Given this list of marker genes VAV1, KRAS, LYN, GRB2, EPOR, EPO, IRS2, CRKL, HRAS (HRas proto-oncogene, GTPase), SHC1, NRAS, SOS1, RAPGEF1, JAK2, here is a description of the gene set: Erythropoietin activates RAS Human Gene Set: REACTOME_ERYTHROPOIETIN_ACTIVATES_RAS studied in species Homo sapiens